The following is a description of a gene set: part of: Translation electronically inferred by orthology from the curated human pathway This event has been computationally inferred from an event that has been demonstrated in another species.<p>The inference is based on the homology mapping from PANTHER. Briefly, reactions for which all involved PhysicalEntities (in input, output and catalyst) have a mapped orthologue/paralogue (for complexes at least 75% of components must have a mapping) are inferred to the other species. Reactome Pathway: Mitochondrial translation studied in species Mus musculus, and this is the list of marker genes: Mrps16, Mrpl22, Mrpl13, Aurkaip1, Mrps7, Mrpl53, mt-Nd3, Mrps17, Mrpl16, Mrpl21, Mrpl32, Oxa1l, Mrps36, Mrps33, Mrpl35, Mief1, Mrpl36, Mrpl1, Mrps26, Mrpl14, Mrpl23, Mrrf, Mrpl54, mt-Nd4l, Mrpl4, Mrpl55, Mrpl57, mt-Nd6, Mrpl27, Mrpl40 (mitochondrial ribosomal protein L40), Malsu1, Mrpl15, Mrpl3, Mrps21, Mrps35, Mrpl2, Mrpl28, Mtrf1, Mrps12, Mrpl34, mt-Atp8, Mrpl47, Mrpl11, Mrpl58, Mrpl52, mt-Cytb, Mrpl17, Mrps18c, Mrps6, Mrpl33, Mrpl51